Given this list of marker genes Ring1, Rad52, H4c14, Smc3, Pias4, Rae1, Zfp131, Aurkb, Stag1, Nsmce4a, Bmi1, Nup133, Cbx8, Aaas, H4c2, Sumo1, Cbx2, Brca1, Trim27, Top2a, Nr1h4, Nup42, L3mbtl2, Pcgf2, H4c1, Nop58, Nr1i2, H4c6, Hdac7, Nup85, Nup93, Trp53bp1, Mta1, Blm, Nsmce2, Park7, Sin3a, Vhl, Smc6, H4c18, Thrb, Ndc1, Rpa1, H4c12 (H4 clustered histone 12), Mrtfa, Hnrnpk, Mdc1, Cbx4, Mbd1, H4c3 (H4 clustered histone 3), Nup155, H4c17, Daxx, Nfkbia, H4c4, Ep300, Pcna, Dnmt1, Eid3, Tdg, Esr1, Ncoa1, Mitf, Ar, Nup58, Vdr, Rad21, H4c9, Npm1, Nup210, H4c8, Seh1l, Nfkb2, Foxl2, Dnmt3b, Rara, Nup54 (nucleoporin 54), Ing2, Xpc, Satb2, Rela, Nsmce3, Hdac4, Phc1, Nr5a1, Nup205, Scmh1, Hic1, Nr3c1, Rnf168, H4c11, Nsmce1, here is a description of the gene set: part of: SUMOylation studied in species Mus musculus Reactome Pathway: SUMO E3 ligases SUMOylate target proteins This event has been computationally inferred from an event that has been demonstrated in another species.<p>The inference is based on the homology mapping from PANTHER. Briefly, reactions for which all involved PhysicalEntities (in input, output and catalyst) have a mapped orthologue/paralogue (for complexes at least 75% of components must have a mapping) are inferred to the other species. electronically inferred by orthology from the curated human pathway